Given this list of marker genes OPRPN, DRP2, SDC3, ELOVL6, GAS7, CDH5, ZFP41, LCN1, TMEM239, ZNF385B, CD3E, TRIM29, KLF8, IQSEC2 (IQ motif and Sec7 domain ArfGEF 2), ZFAND3 (NCBI Gene Id 60685), XKR4, COX7A2L, MMAB, TLX1, MRAS, NRARP, TRAPPC9, ACAP3, SLC36A1, MBTD1, NTSR1, ZER1, GIPC3, RGMA, NFIX, L1CAM, FRMPD4, SAP30BP, SFTPB, USP30, MFN2, FAAH, NIT1, ZCCHC24, POLR2D, BCL2L1, LARP1, CLEC16A, ADGRL1, DPY19L1, KCNIP3, CNPY3, PMEPA1, KREMEN1, ZNF609, ZNF540, RNMT, HAP1, PLXDC2, ZBTB46, STK40, TMEM127, CLIP2, VAV3, CDR2L, ADGRD1, NKAIN2, FOSL1, GJA3, NCOR1, PRAMEF25, POM121C, PDZRN3 (PDZ domain containing ring finger 3), FAM114A2, SND1, VDR, TRIM66, PYROXD1, SMG6, ANKRD52, FAM53B, INHBC, CFAP61, RBM38, ANKS3, PML, MEGF9, TXLNA, SEMA4G, KIAA0930, DISC1, FERRY3, MYO1C, ENTR1, WARS1, PDE4D, VPS37C, CCDC65, REXO1, POM121, TMCC2, SLC7A1, ARNT2, here is a description of the gene set: from publication Chen Y, Wang X (PMID 31504780) studied in species Homo sapiens Human Gene Set: MIR6829_5P Genes predicted to be targets of miRBase v22 microRNA hsa-miR-6829-5p in miRDB v6.0 with MirTarget v4 prediction scores > 80 (high confidence targets).